The following is a description of a gene set: Any process that increases the rate, frequency, or extent of a response to cytokine stimulus. Mouse Gene Set: GOBP_POSITIVE_REGULATION_OF_RESPONSE_TO_CYTOKINE_STIMULUS species: Mus musculus, and this is the list of marker genes: Tslp, Irgm2, Cd40, Hpx, Ube2k (ubiquitin-conjugating enzyme E2K), Edn1, Cpne1, Crebrf, Ticam2, Sting1, Zbp1, Fadd, Txk, Mmp8, Usp27x, Axl, Rbm47, Irf7, Il1r1, Med1, Nlrp6, Trim6, Ifih1, Usp29, Pafah1b1, Casp1, Wnt5a, Igtp, Prkn, Hif1a, Parp9, Mmp12, Cd300lf, Gfi1, Trim41, Ripk1, Rigi, Laptm5, Gas6, Trim56, Trim44, Il7, Ikbke, Csf1, Parp14, Tlr4, Rnf185, Trim32, Trem2, Traf2, Mavs, Dhx9, Taf9, Lsm14a, Tbk1, Tlr2, Adam17, C1qtnf4 (NCBI Gene Id 77240), Irgm1, Nlrc5, Cd74, Hspa1b, Casp4, Irf3, Cxcr4, Ripk2